The following is a description of a gene set: from publication Rayner KJ, Sheedy FJ, Esau CC, Hussain FN, Temel RE, Parathath S, van Gils JM, Rayner AJ, Chang AN, Suarez Y, Fernandez-Hernando C, Fisher EA, Moore KJ (PMID 21646721) Inhibition of miR-33 results in increased cholesterol efflux and HDL-cholesterol levels in mice. In this study we examined the effect of miR-33 inhibition in a mouse model of atherosclerosis and observed significant reduction in atherosclerotic plaque size. At the end of the study, gene expression in macrophages from the atherosclerotic plaques was assessed. The results demonstrated a reduction in inflammatory gene expression and increased levels of mRNAs containing miR-33 binding sites. Genes down-regulated in atherosclerosis macrophages: anti miR-33 versus anti miR. studied in species Homo sapiens Human Gene Set: GSE28783_ANTI_MIR33_VS_CTRL_ATHEROSCLEROSIS_MACROPHAGE_DN, and this is the list of marker genes: FRY, FNTB, BICD1, POM121L6P, SEMA3F, SPICE1, PIK3R3, SLC19A2, PAXIP1, SLC35D1, ADH5, ATP6V1H, CHEK1, SDS, SCHIP1, BTK, CCL15, SUCLG2, MAB21L1, AKAP6, HOXD3, ADH1B, GSTA4, ZNF629, BGLAP, RNASEH2B, SPTBN2, CCL23, EDNRA, ARFGEF2, CUL5, GGCX, ALDH3B1, SCAF8, PCDHA12, EMP2, PTGIS, CEACAM8, PCSK5, TSPO, MBL2, KRTAP26-1, MAP7, TRIM33, STMN1, PER2, STAR, PDZK1, TNFRSF17, TLR2, UNC13B, ANXA9, APOBEC3F, HOXB7, ALDH5A1, FXR1 (FMR1 autosomal homolog 1), DHRS12, GULP1 (NCBI Gene Id 51454), ZWINT, PLA2G15, LRIG1 (NCBI Gene Id 26018), SPTLC2, RLN1, TRPC6, IL13RA1, SMPD2, RPL15, SH3BGR, ELAVL4, ATP10D, LIG1, BPY2, KDELR1, KIF11, URB1, CMAHP, CILK1, IL17A, ZNF460, ZIC3, OAZ2, CSNK2A2, CBL, UGT8, BRSK2, IFNA14, RAPGEF1, DYRK3, SMPDL3A, NID2, STEAP1, STC1, HSD17B2, TRIM23, SEC24D, SLC26A3, ATP7B, ADGRG2, SPIN2A, ST7, GNRHR, MAGEA4, DACH1, NPHP4, ANGPT1, SPAST, PEG3, KRT34, BAZ1A, PLPPR4 (NCBI Gene Id 9890), IDE, POU3F4, SMG7-AS1, CEACAM5, ZNF208, IFIT1, DSG1, SERPINI1, PGLYRP1, CXCL1, ZKSCAN5, RNASE2, TMT1A, HOPX, XCL2, AFF2, INPP5A, ARHGEF17, ACKR1, GRIA3, LYZ, HOXA1, NUP153, ZFP69B, CD24, RSAD2, DCX, CDKL1, BAZ2B, TAX1BP3, COL8A1, SQLE, ZNF134, IL4, EPPIN, PACRG, PANX1 (pannexin 1), SYNJ1, OR2F1, CST7, TNFSF9, ZFR2, SLC25A16, MAGEA5P, RPL28, GLRB, SCAPER, CXCR2, GCA, KCTD17, MB, CEACAM7, ACP3, FAM149B1, ZC3H13, GCLC, ZNF20 (NCBI Gene Id 95841), CXCL5, PTPRB, GP1BA, ERG28, MTMR1, ATP5MC2, PTPRN2, NTSR1, DMP1, RGS13, MFAP5, PLK4, DMXL2, H3C4, XK, RNF6, PRUNE2, FOXF2, MTUS2, CADM3-AS1, ERC2, SLC17A1, NCAN, CASK, CCR1, GLRA3, DNTTIP2, ATP9A, CGA, ENPEP, CENPE